The following is a description of a gene set: Mouse Gene Set: GOCC_CLEAVAGE_FURROW The cleavage furrow is a plasma membrane invagination at the cell division site. The cleavage furrow begins as a shallow groove and eventually deepens to divide the cytoplasm. species: Mus musculus, and this is the list of marker genes: Pkn2, 4930544G11Rik, Pstpip1, Wdr73, Kif20a, Nf2, Spn, Rab11fip4, Psd, Diaph3, Septin2, Zfyve19, Rala, Ssh1, Pkn1, Nde1 (nudE neurodevelopment protein 1), Myh10, Stambp, Fsd1, Spire2 (NCBI Gene Id 234857), Rhob, Ect2, Spire1, Icam2, Cit, Rab11fip3, Pdxp, Rhoc, Pitpnm1, Lima1, Men1, Plcd3, Myh9, Septin5, Htr3a, Septin7, Tpm3, Or2a7, Psd3, Mylk, Racgap1, Ankrd45, Dctn3, Plk4, Katnbl1, Arf6, Rdx, Septin6, Mastl, Rab11a, Rab21, Svil, Hmcn1, Rhoa, Ppp1cc, Plekhg6, Psd2, Hmcn2, Cep55